The following is a description of a gene set: Any process that modulates the frequency, rate or extent of receptor internalization. Mouse Gene Set: GOBP_REGULATION_OF_RECEPTOR_INTERNALIZATION studied in species Mus musculus, and this is the list of marker genes: Iqsec1, Syk, Ahi1, Lrrtm2, Sh3gl2, Lrrtm1, Dab2, Insr, Dkk1, Ophn1, Mdm2, Akap5, App, Nsf, Ptpn5, Angpt1, Egf, Anxa2, Pard3, Mkln1, Sirt2, Ubqln2, Magi2, Drd3 (dopamine receptor D3), Hpca, Tspan7, Hamp2, Flot1, Pcsk9, Rnf220, Ankrd13d, Necab2 (NCBI Gene Id 117148), Atad1, Synj1, Arf1, Ankrd13b, Nedd4l, Tamalin, Aplnr, Wnt3a, Fmr1, Rala, Hap1, Syt17, Rnf216 (ring finger protein 216), Nrg1 (NCBI Gene Id 320603), Gsg1l, Plcg2, Susd4, Nedd4, Arrb2, Drd4, Synj2bp, Apln, Apela, Usp46, Sdcbp, Ncdn, Scrib, Vac14, Rin3, Ntf3, Lrpap1, Hamp, Lrp1, Atxn2, Ap2m1, Rspo1, Ankrd13a, Cblb, Pacsin1, Mtmr2, Rabep1, Arc, Drd2, Napb, Lpar1, Itgb3, Ppp3r1, Sele, Pip5k1c, Dlg4, Plk2, Arrb1 (arrestin, beta 1), Cd63, Hip1, Dtnbp1, Numb, Efnb2, Pick1, Wdr54, Arap1, Sfrp4, Tbc1d5, Vegfa, Grem1